Given this list of marker genes CEP135, SAPCD2, ECT2, TAF5, XPNPEP1, KIF20A, RAB15, ZMYM1, SCAF8, TTL, PBX3, CCDC93, SCLT1, SUSD3, EME1, CCDC34, WDR90, DEK, TK1, LMO7, LUC7L3 (NCBI Gene Id 51747), IMPA2, MYBL1, NEIL3, KIF18A, ZNF518A, ALPK1 (alpha kinase 1), KANK2, CENPU (centromere protein U), CDCA3, CAMSAP1, ZMYND19, CCNE1, HP1BP3, TMSB15A, KTN1 (kinectin 1), NUCKS1, CENPE, PRKAR2B, CHTF18, EPS8, CDC25C, CRYBG1, CCDC141, MXD3, SDR16C5, NUF2, NCAPG2, SCARNA15, UBE4B, CASZ1, FANCL, TCL6 (NCBI Gene Id 124903372), WDHD1, ELOA-AS1, WDR5, ACYP1, POLQ, CADPS, AGBL5, PLK4, SYNE2, PIDD1, AICDA, CCDC82, PSIP1, PLCL2, TCF12, TCF19, CDK19 (cyclin dependent kinase 19), ORC1, TASOR2, CCND3, PEX5, CCNB2, ZNF385B, NCAPG, MELK, FAR2P2, GFOD1, IFT80, DEPDC1, UHRF1, IQCD, RFC3, GPSM2, ATP13A5, SPDL1, SASS6, RALBP1, BUB1B, BRD3, E2F1, WASF3, ORC6, TIAM1, CYTH2, LPP (NCBI Gene Id 4026), HEMGN, CENPA, ZNF831, CENPI, SNTB2, SUV39H1 (SUV39H1 histone lysine methyltransferase), H2AX, ATAD2, HES6, C1orf35, DCLRE1C, AURKA (aurora kinase A), CLDN23, STAG1 (STAG1 cohesin complex component), SLC2A5, CHN2, TTK, NUSAP1, C3orf52, TBC1D31, BUB1, CEP57L1, ZMYM2, ZNF367, NSD2, SFXN4, USP34, LRRC37A2, CDC20, CSPP1, ROCK2, KCTD7 (NCBI Gene Id 154881, potassium channel tetramerization domain containing 7), SLC35E3, ZFYVE19, PGBD5, PIF1, PCDH9, SANBR, PCNX1, RBSN (NCBI Gene Id 64145), RDM1, FAM110A, ERCC6L, TMSB15B, STK40, ANKRD10, ZWINT, PNMA1, DIS3L, STMN1, BACH2, HMGB3P1, PRC1, FANCG, TOPBP1, MPHOSPH9, TMPO-AS1, CCDC18, RTKN2, MAZ, C5 (NCBI Gene Id 727), PABIR2, SPC24, CEP192, HAUS8, GAS2L3, REXO5 (RNA exonuclease 5), LIMK2, ERI2, SNW1, DDX11, FAM83D, ANLN, DEPTOR (DEP domain containing MTOR interacting protein), HMGB3, DDB2, UBR5, POLH, BCR, E2F7, WAC, KYAT1, PSRC1, PSMC3IP, PALLD, USP30, NDE1, TACC3, NEK1, SUGP2, MTFR2, CDC25A, NCKIPSD, POU4F1, KMT2A, MFHAS1, here is a description of the gene set: STAT3, an essential transcription factor with pleiotropic functions, plays critical roles in the pathogenesis of autoimmunity. Despite recent data linking STAT3 with inflammatory bowel disease, exactly how it contributes to chronic intestinal inflammation is not known. Using a T cell transfer model of colitis we found that STAT3 expression in T cells was essential for the induction of both colitis and systemic inflammation. STAT3 was critical in modulating the balance of T helper 17 (Th17) and regulatory T (Treg) cells, as well as in promoting CD4+ T cell proliferation. We used chromatin immunoprecipitation and massive parallel sequencing (ChIP-Seq) to define the genome-wide targets of STAT3 in CD4+ T cells. We found that STAT3 bound to multiple genes involved in Th17 cell differentiation, cell activation, proliferation and survival, regulating both expression and epigenetic modifications. Thus, STAT3 orchestrates multiple critical aspects of T cell function in inflammation and homeostasis. Human Gene Set: GSE21670_UNTREATED_VS_TGFB_IL6_TREATED_CD4_TCELL_UP species: Homo sapiens Genes up-regulated in CD4 T cells: medium versus TGF beta and IL6. from publication Durant L, Watford WT, Ramos HL, Laurence A, Vahedi G, Wei L, Takahashi H, Sun HW, Kanno Y, Powrie F, O'Shea JJ (PMID 20493732)